The following is a description of a gene set: Human Gene Set: GOBP_NEGATIVE_REGULATION_OF_ACTIVATED_T_CELL_PROLIFERATION species: Homo sapiens Any process that stops, prevents or reduces the rate or extent of activated T cell proliferation., and this is the list of marker genes: CD274, SCRIB, LAPTM5, FOXP3, ARG1, LILRB4, PRNP, LGALS9, MIR181C, PDCD1LG2, BTN2A2, RC3H1, CASP3, PRKAR1A, CRTAM, LRRC32